The following is a description of a gene set: species: Homo sapiens The synthesis of ribosomal RNA (rRNA), any RNA that forms part of the ribosomal structure, from a DNA template. Human Gene Set: GOBP_RRNA_TRANSCRIPTION, and this is the list of marker genes: TCOF1, CDKN2A, MTOR, GTF3C4, BRF1, POLR1B, POLR2E, POLR1F, GTF3C3, MACROH2A1, POLR1G, GTF3C5, GTF3C6, NCL, DDX11, SIRT7, MARS1, ANG, ERCC6, SMARCB1, GTF3A, NOL11, NOP53, ERCC2, GTF3C2, TOP1, TAF1B, GTF2H5, IPPK, CAVIN1, POLR1E (RNA polymerase I subunit E, NCBI Gene Id 64425), POLR1D (RNA polymerase I and III subunit D), SMARCA4 (NCBI Gene Id 6597), PIH1D1, NIFK, DEDD, PWP1, MACROH2A2, NPM3, TP53, SPIN1, GTF3C1